The following is a description of a gene set: species: Mus musculus Reactome Pathway: The fatty acid cycling model part of: Mitochondrial Uncoupling electronically inferred by orthology from the curated human pathway This event has been computationally inferred from an event that has been demonstrated in another species.<p>The inference is based on the homology mapping from PANTHER. Briefly, reactions for which all involved PhysicalEntities (in input, output and catalyst) have a mapped orthologue/paralogue (for complexes at least 75% of components must have a mapping) are inferred to the other species., and this is the list of marker genes: Slc25a14, Ucp2, Ucp3, Ucp1